The following is a description of a gene set: studied in species Homo sapiens Human Gene Set: GOBP_RETROGRADE_NEURONAL_DENSE_CORE_VESICLE_TRANSPORT The directed movement of neuronal dense core vesicles along axonal microtubules towards the cell body., and this is the list of marker genes: KIF1B, KIF1C, KIF5A, KIF5B, KIF1A